Given this list of marker genes Gnas, Chchd2, Ccl17, Cdkn1a, Cst3, Bcl2a1b, Bcl2a1d, Bcl2a1a (B cell leukemia/lymphoma 2 related protein A1a), here is a description of the gene set: from publication Cui A, Huang T, Li S, Ma A, Pérez JL, Sander C, Keskin DB, Wu CJ, Fraenkel E, Hacohen N (PMID 38057668) species: Mus musculus Genes positively differentially expressed in cell type: Langerhans upon treatment with cytokine: IL-7 in mouse lymph nodes in vivo. Cytokines mediate cell-cell communication in the immune system and represent important therapeutic targets. A myriad of studies have highlighted their central role in immune function, yet we lack a global view of the cellular responses of each immune cell type to each cytokine. To address this gap, the authors created the Immune Dictionary, a compendium of single-cell transcriptomic profiles of more than 17 immune cell types in response to each of 86 cytokines (>1,400 cytokine-cell type combinations) in mouse lymph nodes in vivo. A cytokine-centric view of the dictionary revealed that most cytokines induce highly cell-type-specific responses. For example, the inflammatory cytokine interleukin-1β induces distinct gene programmes in almost every cell type. A cell-type-centric view of the dictionary identified more than 66 cytokine-driven cellular polarization states across immune cell types, including previously uncharacterized states such as an interleukin-18-induced polyfunctional natural killer cell state. Mouse Gene Set: CUI_LANGERHANS_IL7_RESPONSE_UP